The following is a description of a gene set: species: Homo sapiens Human Gene Set: HP_ABNORMAL_FEMORAL_NECK_MORPHOLOGY Abnormal femoral neck morphology An abnormality of the femoral neck (which is the process of bone, connecting the femoral head with the femoral shaft)., and this is the list of marker genes: PRG4, RBM8A, POC1A, ARCN1, WNK3, ZMPSTE24, CHD4, CANT1, GLB1, SRP54, RPS6KA3, TMEM53, AFF3, MTX2 (metaxin 2), GNPNAT1 (glucosamine-phosphate N-acetyltransferase 1), TGFB3, HNRNPR (heterogeneous nuclear ribonucleoprotein R), SERPINF1, COMP, LMX1B, IHH, DVL1, SLC39A13, EED, COL27A1, SLC4A10, CRKL, MMP9, RTL1, MATN3, CBFB, BCR, CCN6, DNAJC21, GJB6, EXT2, SLC26A2, PIK3C2A, FUCA1, EXT1, XYLT1, PDE4D, COL9A3, ATP6V0A2, TBX4, HNRNPK, SLC12A2, GALNS (NCBI Gene Id 2588), HNRNPH1, RAB23, TGFB1, SLC2A10, MAPK1, ATRX, RAB33B, COL10A1, DYM, NANS, PRKAR1A, ABCC9, CSGALNACT1, GNPTAB, RUNX2, RMRP (RNA component of mitochondrial RNA processing endoribonuclease), COL9A1, GLI3, TRAPPC2, RAB3GAP2, SLC35B2, GJB2, CTC1, CFAP410, ADAMTSL2, RPL13, EIF2AK3, MEG3, CRTAP, PCNT, EZH2, EXOC6B, GTF2E2, COG8, B3GALT6, MAN2B1, RNU4ATAC, FN1, DMP1, FKBP10, TOMM7, UFSP2, ERCC6, BGN, ORC1, SLC10A7, DDRGK1, FAH, KDELR2, ACVR1, BMPR1B, MGAT2, LYSET, IDUA, OTUD5, TONSL, CHST3, ADAMTS2, UFC1, KCNJ8, LMNA, EXTL3, POP1, HSPG2, DLK1, COG1, COL2A1, DVL3, ARID1B, TMEM67, COL1A2, MBTPS1 (NCBI Gene Id 8720), KIF22, AIFM1, RSPRY1 (ring finger and SPRY domain containing 1), SHOX, COL9A2, IFIH1, TTI1, MEGF8, COL11A1, NKX3-2, COL1A1, IFT140, FZD2, CCDC47 (coiled-coil domain containing 47), LBR, STXBP1, TRPV4, RAD21, NGLY1, COG4, SIL1, TCIRG1, SLC35A2, UBE3C, TRIP11 (thyroid hormone receptor interactor 11), B4GALT7, ENPP1, FLNB, SBDS, FGFR3, PEX5, PTH1R, FLNA, PCYT1A, ORC6, ATP7A, MMP13, NFIX (nuclear factor I X), WNT5A, NRCAM